Given this list of marker genes Marchf7, Sdcbp, Plk1, Sipa1l1, Hif1a, Styxl1, Cnot2, Cnot6l, Ralb, Yap1, Mapk15, Wnt5a, Nbdy, Lrfn4, Abi3, Cdk5rap2, Moap1, Hspa1a, Hck, Atg3, Dnm2, Chmp3, Arhgap35, Pip4k2b (phosphatidylinositol-5-phosphate 4-kinase, type II, beta), Ptprd, Patl2, Rbm14, Ptk2b, Plk2, Rab1b, Rab3ip (NCBI Gene Id 216363), Tbc1d7, Chmp5, Htt, Mtor, Becn1, Nf2, Spice1, Odad3, Ulk1, Mns1, Mfn2, Fez1, Lrrtm1, Wdr45, Mapk8, Wdpcp, Lrrc4b, Arf4, Ccsap, Fgfr1 (NCBI Gene Id 14182), Hsf1, Il1rap, Intu, Rp1, Hap1, Odf2, Elapor1, Spag5, Efnb1, Nlgn1, Rab11a, Lrfn1, Ttbk2, Kat2a, Arhgef5, Dynlt2b, Npm1, Syne2, Il5, Odf2l, Lrrk2, Rnf5, Snx30, Mark4, Mdm1, Lpar1, Mcidas, Drg1, Stam, Arpc2, Ccdc15, Ppp1r35, Tbc1d14, Akt1, Nupr1, Mir129-2, Nptxr, Rnf186 (ring finger protein 186), Scfd1, Snx4, Mtmr3, Sptbn2, Nrxn1, Pan2, Chek2, Chmp1b, Atg5, Pdcd6ip, Mapk9, Cep295nl, Cep135 (NCBI Gene Id 381644), Gsk3b, Fscn1, Chmp4b, Saxo1, Chmp1a, Arhgef9, Mtm1, Prkaa2, Chmp7, Rhoa, Mak, Ehmt2, Trappc12, Dync2li1, Sdc1, Ezr, Tnf, Src, Poc1b, Septin9, Sass6, Hspa1b, Lcp1 (NCBI Gene Id 52646), Alms1 (NCBI Gene Id 381791), Smad4, Dync1h1, Lats1, Cep295, Cript, Cyld, Rab11fip3, Tchp (NCBI Gene Id 77832), Ubqln2, Rdx, Caskin1 (NCBI Gene Id 71822), Luzp1, Syne1, Tpr, Gdi2, Ccdc88a, Ift20, Pip4k2c, Chmp6, Kif24, Csf2, Tesk1, Limk2, Sec22b, G3bp1, Cep120, Bbs4 (Bardet-Biedl syndrome 4), Pip4k2a, Gap43, Sdccag8 (serologically defined colon cancer antigen 8), Sh3glb1, Abi3bp, Ripor2, Msn, Adamts16, Cdkl1, Pan3, Cbln1, Vps4b, Cep76, Evi5l, Snx18, Kat2b, Numa1, Rcc1, Snx7, Tmem39a, Rnf4, Dcdc2a, Trim37, Ephb2, Cep97, Fuz, D7Ertd443e, Arhgef2, Ccp110, Cdk10, Rab3gap1, Cnot1, Prickle1, Cdkl5, Kif9, Entr1, Tsg101, Pqbp1, Chmp2b, Tmem67, Lima1, Wrap73, Usp10, Wipi1, Kctd17, Gpsm2, Tapt1, Cenpj, Atmin, Eml3 (echinoderm microtubule associated protein like 3), Prkaa1, Lrrtm2, Fez2, Pikfyve (NCBI Gene Id 71407), Caprin1, Prickle2, Crocc, Cep192, Ift46, Ptprs (NCBI Gene Id 19280), Grid2, Wdr44, Lrsam1, Dzip1, Cnot6, Zmynd10, G3bp2, Smcr8, Ift140, Abl1, Tbc1d12, Senp6, Rabep2, Hnrnpu, Dynll1, Cav3, Atg2a, Chmp2a, Vps11, Nup62, Sdc4, Phf23, Pink1, Mphosph9, Ift88, C9orf72, Plk4, Stil, Ubap2l, Chmp4c, Rab3gap2, Tbc1d30, Trim32, Cntrob, Chmp1b2, Noto, Stx18, Gsn, here is a description of the gene set: Mouse Gene Set: GOBP_REGULATION_OF_ORGANELLE_ASSEMBLY Any process that modulates the frequency, rate or extent of organelle assembly. species: Mus musculus